Given this list of marker genes MAPK4, MAPK13, MAP2K7, MAPK6, MAPK15, MAPK10, MAP3K7, MAPK3, MAPK11, MAPK8, MAPK1, MAPK12, MAPK14, NLK, MAPK7, MAPK9, here is a description of the gene set: Human Gene Set: GOMF_MAP_KINASE_ACTIVITY Catalysis of the reaction: protein + ATP = protein phosphate + ADP. This reaction is the phosphorylation of proteins. Mitogen-activated protein kinase; a family of protein kinases that perform a crucial step in relaying signals from the plasma membrane to the nucleus. They are activated by a wide range of proliferation- or differentiation-inducing signals; activation is strong with agonists such as polypeptide growth factors and tumor-promoting phorbol esters, but weak (in most cell backgrounds) by stress stimuli. studied in species Homo sapiens